The following is a description of a gene set: This event has been computationally inferred from an event that has been demonstrated in another species.<p>The inference is based on the homology mapping from PANTHER. Briefly, reactions for which all involved PhysicalEntities (in input, output and catalyst) have a mapped orthologue/paralogue (for complexes at least 75% of components must have a mapping) are inferred to the other species. species: Mus musculus electronically inferred by orthology from the curated human pathway part of: DNA Replication Pre-Initiation Reactome Pathway: Assembly of the pre-replicative complex, and this is the list of marker genes: Psmc6, Orc5, Rps27a, Cdc23, Anapc7, Psmb5, Psmc5, Anapc15, Orc4, Psmb4, Psma6, Kpna6, Ube2e1, Gmnn, Psma7, Psma2 (proteasome subunit alpha 2), Cdc6, Orc1, Psmb6, Psma1, Cdc26, Orc3, Psmd1, Psma5, Anapc2, Kpnb1, Fzr1 (NCBI Gene Id 56371), Psmc1, Psmc4, Kpna1 (karyopherin subunit alpha 1), Psmc2, Ube2d1, Psmb7, Psma4, Mcm4 (minichromosome maintenance complex component 4), Psma3, Psmd7, Psmc3, Ubb, Mcm8, Ube2c (ubiquitin-conjugating enzyme E2C), Mcm2, Ube2s, Psmd6, Psmd13, Psmd12, Mcm7, Anapc10